Given this list of marker genes MIR4766, KRT8, HOXC6, PTEN (NCBI Gene Id 8037), SLBP, CDCA7L, PTDSS1, TMEM248, RNU4-1, INO80C, KDSR, TJP3, ATP8A1-DT, PADI1, BCL2L2, DAP3, RNU4-2, RNVU1-14, YY1AP1, FUT10, TTI2, CFAP221, HOXC9, CLASP1, CENPU, SMARCD2, SUCO, LRRC4B, IFT52, EPS15, INTS10, RTBDN, MEMO1, WWOX, ARID1A, BCL2L2-PABPN1, KANSL3 (NCBI Gene Id 55683), RNU4ATAC (RNA, U4atac small nuclear), FOS, MTERF3, E2F6, ATP8A1, SYT7, ATG101, RNVU1-15, SLC2A1, here is a description of the gene set: Human Gene Set: NUFIP1_TARGET_GENES Genes containing one or more binding sites for (NUFIP1) in their promoter regions (TSS -1000,+100 bp) as identified by GTRD version 20.06 ChIP-seq harmonization. from publication Yevshin I, Sharipov R, Kolmykov S, Kondrakhin Y, Kolpakov F (PMID 30445619) species: Homo sapiens